The following is a description of a gene set: species: Homo sapiens Genes predicted to be targets of miRBase v22 microRNA hsa-miR-216b-5p in miRDB v6.0 with MirTarget v4 prediction scores > 80 (high confidence targets). Human Gene Set: MIR216B_5P from publication Chen Y, Wang X (PMID 31504780), and this is the list of marker genes: WWOX, CFAP298 (NCBI Gene Id 89757), TBX2, LRP8, KDM7A, DCUN1D4, PLXNA1, CRY2, ITPRIPL2, FNDC3B, THAP6, ISCA1, ARFIP1, ANXA10, CASK, AVPR1A, NEUROG2, YIPF5, TBL1XR1 (NCBI Gene Id 81612), IKZF2, TMPRSS12, MPLKIP, GTF3C3, ENAH, KCNT2, GLRB, HK2, SREK1IP1, NCOA3 (nuclear receptor coactivator 3), BCL2L11, PXN, RRM2B, PDHA2, CDC73, CDR2L, APBB2, PRDM2, GCFC2, PRLR, B4GALT6, SNX30, FAM131B, LCOR, VAPA, CLDN16 (claudin 16), PMP2, INSYN2A, TTC14, NRK, NPAS2, SMAD1, HLF, RAP1B (NCBI Gene Id 5908), KLF9, ENC1, CNTN3, PWP1, PLEKHA5, DNAH14, CASP10, HOXD13, CCDC50 (NCBI Gene Id 338335), IQCJ-SCHIP1, IGSF11, LIMA1, MCM4, NKAPD1, WDR12, GBP5, ANKRD42, USO1, DIXDC1, SLC33A1, MPHOSPH6, EDNRA, ACSL6, TMED5, PCMTD1, GAD1, NTRK2, RNF146, MSR1, TPM3, SLC50A1, ZNF148, MLLT3 (NCBI Gene Id 4300), DNAJB9, SPHKAP, SCHIP1, TMEM199, FAM151B, TMEM161B